The following is a description of a gene set: Mouse Organogenesis Cell Atlas (MOCA) DE_gene_main_cluster.csv, fold.change>=1.5, qval<0.05, pval<0.05 studied in species Mus musculus Mouse Gene Set: DESCARTES_ORGANOGENESIS_LIMB_MESENCHYME from publication Cao J, Spielmann M, Qiu X, Huang X, Ibrahim DM, Hill AJ, Zhang F, Mundlos S, Christiansen L, Steemers FJ, Trapnell C, Shendure J (PMID 30787437), and this is the list of marker genes: Gm9143, 1500009L16Rik, Mecomos, Pitx1, Cped1, Tanc1, Fgf10 (fibroblast growth factor 10), Msx1, Hoxa11os, Grem1, Tbx4, Hoxa13, Gm10258, Lmx1b (LIM homeobox transcription factor 1 beta), Cpa2, 9430024E24Rik, Gm20275, Hoxd12, Tbx15, Mecom, Hand2, Gm31727, Hoxd13, Tmem119, Hoxd10, Prrx2 (NCBI Gene Id 20204), A530021J07Rik, Hoxa10 (NCBI Gene Id 15395), Hottip, Vegfd, Hoxa9, Sox5os4, Hoxd11, BB557941, Spry4, Zfp689, Asb4, Cpne1, Creb3l4, Wnt5a, Gm14055 (predicted gene 14055), Hoxa11, Galnt5